Given this list of marker genes MICU1, MICU2, MICU3, MCUB, SMDT1 (single-pass membrane protein with aspartate rich tail 1), MCU, here is a description of the gene set: species: Homo sapiens Human Gene Set: GOCC_UNIPLEX_COMPLEX A calcium channel complex in the mitochondrial inner membrane capable of highly-selective calcium channel activity. Its components include the EF-hand-containing proteins mitochondrial calcium uptake 1 (MICU1) and MICU2, the pore-forming subunit mitochondrial calcium uniporter (MCU) and its paralog MCUb, and the MCU regulator EMRE.